The following is a description of a gene set: studied in species Homo sapiens An abnormal increase in the molar ratio of lactate to pyruvate in the blood circulation. Elevated lactate:pyruvate ratio Human Gene Set: HP_ELEVATED_LACTATE_PYRUVATE_RATIO, and this is the list of marker genes: GFM1, MRPL3, UQCC3, NDUFA10, TMEM126B, BCS1L, PDSS1, TSFM, NDUFS4, CYC1, PRORP, IBA57, NDUFB10, HS6ST2, MDH2, SUCLG1, NDUFA9, MPV17, TRMT10C, SCO2, SDHA, COQ8A